Given this list of marker genes Tmc8, Mt3, Slc30a2, Slc39a13, Mt1, Zng1, Slc30a1, Tmc6, Slc30a7 (solute carrier family 30 (zinc transporter), member 7), Slc39a10, Slc39a9, Slc30a9, Slc30a8, Slc39a8, Mt4, Mt2, Slc39a4, Hps1, Slc39a6, Sco1, Lck, Slc39a14, Slc39a5, Atp7b, Slc39a7, Ap3b1, Slc1a1, Slc30a5, Slc30a10 (NCBI Gene Id 226781), Atp13a2, here is a description of the gene set: species: Mus musculus A homeostatic process involved in the maintenance of a steady state level of zinc ions within a cell. Mouse Gene Set: GOBP_INTRACELLULAR_ZINC_ION_HOMEOSTASIS